The following is a description of a gene set: Human Gene Set: GSE22025_UNTREATED_VS_TGFB1_AND_PROGESTERONE_TREATED_CD4_TCELL_UP Genes up-regulated in CD4 T cells: untreated versus TGFB1 and progesterone. from publication Lee JH, Ulrich B, Cho J, Park J, Kim CH (PMID 21768398) We examined the global gene expression pattern of T cells regulated by progesterone to gain further insights into the regulatory mechanisms of progesterone. We found 325-347 cord blood T cell genes up or down-regulated by P4 in the presence or absence of exogenous TGFb1. Peripheral blood T cells were relatively unresponsive with only 30-genes regulated by P4. IL-6 receptor (IL-6R) expression was greatly down-regulated by progesterone in cord blood, but not PB, T cells. Overall, these differences in gene expression are consistent with the differential responses of cord blood and peripheral blood T cells to progesterone. To gain insights into the differences of progesterone and control dendritic cells, we performed a microarray study and found ~genes regulated by progesterone in dendritic cells. The gene expression information suggests that progesterone has the potential to alter dendritic cell responses to cytokines, chemokine production, and migration which in combination would control T cell differentiation. species: Homo sapiens, and this is the list of marker genes: IGF1, PDE3B, PTPN14, HTT, SMCP, DAPK3 (death associated protein kinase 3), FGL1, KRT8, SLC8A2, GJC1, N4BP2L2-IT2, ATP7B, NACC2, CPEB3, KCNJ12, FRMPD1, PINLYP, DNM3, SRD5A2, B3GALT2, YJU2, TIMELESS, GPR135, NPAS3, CDH22, PRKAA2, PRKD2, APOC1, CYP11B2, ACTC1, SLC9A7, FOXI1, FOXA1, GPA33, PCSK1 (NCBI Gene Id 5122), DMP1, CPQ (carboxypeptidase Q), CTNND2, CAND2, H2AC8, TCEAL4, CHRNA1, DNA2, EPCAM, CYP2B7P, CRACDL, DDN, PCDHA13, RAB4B, TBX6 (NCBI Gene Id 6911), CCN1, DIAPH2, ZNF8, STK19, PPARA, SPAM1, ATP2A3, LINC00837, TCTA, GSTM5, EXOC6B, PTGER2, OIP5, GAB2, CALCOCO1, PCDH1, CXCL12, GSTM3, KCNG1, PPP1R12B, RALGPS1, SIX6, SALL1, ECM2, SYT11, CCDC181, CXCL2, TNNC2, APOF (apolipoprotein F), RNF24, AQP7, CELA2A, CASP9, LSS, CRYBB3, ESRRA, SLCO1A2, STC1, NCF2, COL2A1, BRF1, CDKN1C, RAB35, GBX2, MGAT5, PPIC, INSL4, DDAH2, ATP2B4, PDLIM4, CETP, GABBR1, WASF2, TNFSF9, MEOX2, PPT2, PRF1, CHRD, ANXA3, CLBA1, FAM8A1 (family with sequence similarity 8 member A1), LRP4, KAT8, CTNND1, AHDC1, RFC5, NAA80, DGKQ, FOXO4, AGPAT1, TPM1, FAM50B, PHACTR1, TKTL1, NEUROD2, ETV5, S100A1, BMP10, EIF5AL1, SLC6A4, RAB11B, PAGE1 (PAGE family member 1), CASP2, GABRP, RASL10A, GCAT, IFI30, THBS2, CUX1, CDK3, RLBP1, KHDRBS2, PAPSS2, CLCNKA, CRYAB, ERN1, PTK7, MAP3K9, EXPH5, GP9, PLEKHA6, TWF2, TSC2, NMBR, NID1, NAGLU, TACSTD2, ALOX15B, CPM, SLC2A5, FCGR3A, OGG1, PRKACG, SERPINA7, EPHA3, KLC1, TULP2, NEBL (NCBI Gene Id 51739), TMOD1, RPS6KA1, GCK, RHBDF1, APOBEC1, AGER, VIPR2, FETUB, VCAN, SLC12A5, GJB1, CYP27A1, CYTH1, SCN5A, IP6K1, SELENOW, GATA6, MSTN, GRK3, RNASEH2A, LAMA5, ARAP1, HLX, MDM2, GNAZ, NCAM2, ROBO1, MYH6, SLC19A1, TTLL4, ZNF80, TTPA